The following is a description of a gene set: Human Gene Set: GOBP_VESICLE_TETHERING_TO_GOLGI The initial, indirect interaction between a transport vesicle membrane and the membrane of the Golgi. This interaction is mediated by tethering factors (or complexes), which interact with both membranes. Interaction can occur via direct binding to membrane phospholipids or membrane proteins, or via binding to vesicle coat proteins. This process is distinct from and prior fusion. studied in species Homo sapiens, and this is the list of marker genes: TBC1D23, FAM91A1, C17orf75, WDR11, TRIP11